Given this list of marker genes G6PC3, RBCK1, RNF31, ITGB2, SMARCD2, FCGR3B, CLPB, ARPC5, RAC2, C1QC, here is a description of the gene set: Human Gene Set: HP_NEONATAL_OMPHALITIS An infection of the umbilicus and/or surrounding tissues occurring in the neonatal period. Neonatal omphalitis species: Homo sapiens